The following is a description of a gene set: Mouse Gene Set: GOCC_CYTOSOLIC_REGION studied in species Mus musculus Any (proper) part of the cytosol of a single cell of sufficient size to still be considered cytosol., and this is the list of marker genes: Baiap2, Sh3gl2, Hnrnpab, Calb1, Pias1, Hap1, Senp1, Sncb, Sumo2, Prkca, Prkce, Ppfia2, Ppt1, Gnaq, Htt, Aldoc, Stxbp5, Marcks, Pin1, Sumo3, Plcb3, Eif4ebp1, Calm2, Ncs1, Stxbp1, Usp14, Fbxo45, Ctbp2, Syt1, Mtor, Kif5c, Fabp5, Tnk2, Kif5a, Hnrnpa2b1, Ube3a, Anks1b, Pnkd, Senp6, Pten, Arl6ip5, Plcb1, Prkcg, Camk2a, Kif5b, Homer1, Senp5, Senp7, Sumo1, Pias3, Gdi1, Dag1, Rabep1, Fus, Hspa8, Pin1rt1, Eif4e, Ppp3cc, Nedd4, Prkcb, Ogt, C9orf72, Fmr1, Lrrk2, Erc1 (ELKS/RAB6-interacting/CAST family member 1), Rims3, Trim9, Marcksl1, Camk2d, Prkcd, Dbn1, Ube2i